The following is a description of a gene set: A partial dislocation of one or more intervertebral joints in the cervical vertebral column. studied in species Homo sapiens Human Gene Set: HP_CERVICAL_SUBLUXATION Cervical subluxation, and this is the list of marker genes: GNPTAB, GALNS, MADD, ARSL, FLNB, IDUA, DDR2, GLB1, MMP2, COL2A1, RMRP